Given this list of marker genes F11, GP1BA, GP9, GP5, GP1BB, F9, here is a description of the gene set: Defective F9 activation studied in species Homo sapiens Human Gene Set: REACTOME_DEFECTIVE_F9_ACTIVATION